Given this list of marker genes HERC1 (NCBI Gene Id 8925), INPP4A, PGS1, MVB12B, AMHR2, PCDH8, GPKOW, HSPA1L, CSRP3, DUSP11, HLA-A, NEBL, CROCCP2, OLIG2, RGL2, POLR1E, TREH, GFOD3P, R3HCC1, HSD11B2, UBE2G2, RPS6 (NCBI Gene Id 92956), WDR33 (WD repeat domain 33), MAEA, NOP2, KAT6A, POGZ, MEOX1 (NCBI Gene Id 4222), KAT2A, EIF1AY, DPP4, MPPE1, AQP3, TTC22, CD28, TSPAN2, TSPYL2, GUSBP14, TUG1, MMS19, FAU, ZCWPW1, PCNX2, SPOP, LSAMP, KCNN3, MYH3, PRKCH, CYP3A43, TESK2, TSBP1, MAPKAPK5-AS1, TRAPPC2 (NCBI Gene Id 6399), LIME1, LTK, SLC35E2B, TSPAN32, PASK, TSC22D2, BRD1, PKD1P1, UBE2N, CDR2, ENSG00000274253, EVL, ZNF544, PLXDC1, P2RY10, IRF2, DHX9, RPL23AP32, PCDH12, MAPK8IP3, ZNF250, USP21, LONP2, CUL4A, MACF1, SMAD3, DEF6 (NCBI Gene Id 50619), KHDC1L, CSGALNACT1, PTGER1, FBXW4P1, RPL35A, ZNF337, CEP350, FYN, MAU2, UBIAD1, ANKH, TEX28, RPS17, FOXL1, SEPTIN6, SMYD5, KLF6, FUS, IL11RA, ARGLU1, APBB3, NAP1L4, GABRA3, ZNF500 (NCBI Gene Id 26048), DKKL1, OFD1, MSH6, SLC25A15, NSUN6, SLC2A11, GNL3, SLC2A4RG, GFI1, NFYB, MYBPC1, FLT3LG, HEYL, OBP2A, METTL18, CBLN1, BTN2A1, SLC25A14, PDE4B, RETREG3, IRF4, PRPF38B, RPL4, MTERF1 (NCBI Gene Id 7978), GPX7, VPS13D, CFB, PRKD2, COPS7B, CYP17A1, IL10RA, OR11A1, PTPN2, INTS7, TNFSF18, DDX11, CXCL11, SLC22A1, ARHGEF7, IKZF1, TRPC1, DDX51, MTMR4, MLLT3, PTCH1 (patched 1), PIM2, RPL36, CEP72, HLA-B, POLG, IFFO1, GPATCH8, LDHB, KCNK15-AS1, TMEM204, MIA2, ZNF451, NTHL1, CYP24A1, BBS1, RPL7, RAPGEF6, SAFB, ENSG00000291006, CYFIP2 (NCBI Gene Id 81032), DPY19L2P2, DNAJC24, GALNT10, NFATC3, PLPP1, SLCO1B3, ZNF14, N4BP2L1, TNK2, FAM120C, AKAP7, DENND1C, ARHGAP33, TRANK1, GABPB1-IT1, RPS12, SORCS3, TSPAN6, PKP3, CLUH, CDK5RAP3, IL17A, TESC, HOXB9, EEF1G, AKAP9 (A-kinase anchoring protein 9), PTCD3, PLEKHF1 (pleckstrin homology and FYVE domain containing 1), WNT10B, here is a description of the gene set: species: Homo sapiens from publication Jeffrey KL, Brummer T, Rolph MS, Liu SM, Callejas NA, Grumont RJ, Gillieron C, Mackay F, Grey S, Camps M, Rommel C, Gerondakis SD, Mackay CR (PMID 16474395) In the present study we used Affymetrix oligonucleotide microarrays to produce gene transcription profiles for the major leukocyte types in humans. This comprehensive dataset enabled us to not only establish which genes were expressed in each leukocyte type, but also which genes were expressed in each subset after activation. The used of a comprehensive dataset of gene profiles from all the major human leukocyte subsets enabled a novel and powerful means for identification of genes associated with single leukocyte subsets, or different immune paradigms. Genes down-regulated in comparison of macrophages versus central memory CD4 T cells. Human Gene Set: GSE3982_MAC_VS_CENT_MEMORY_CD4_TCELL_DN